Given this list of marker genes TRIB1, DAB2IP, MAP3K11 (mitogen-activated protein kinase kinase kinase 11), PIN1, ACE, TRIB3, MAPK8IP1, KSR2, TAOK2, TRIB2, here is a description of the gene set: Human Gene Set: GOMF_MITOGEN_ACTIVATED_PROTEIN_KINASE_KINASE_BINDING Binding to a mitogen-activated protein kinase kinase, a protein that can phosphorylate a MAP kinase. species: Homo sapiens